Given this list of marker genes Cables2, Rhbdl3, Asb13, AA414768 (expressed sequence AA414768), Cmpk2, Synj2bp, Nxn, Mdga1, Rwdd3 (NCBI Gene Id 99697), Nfyc, Wars2, Trpm3, Lce3a, Idh1, Abi1, Kdm3b, Tax1bp3, Efcab5, Mbp, Atp2a2, Spen (NCBI Gene Id 56381), Scd1, Aak1, Gal3st2c, Timm9, Hnrnpdl, Pcdh17, Esp18, Ahcyl1, Usp49, Abcf2, Myo1f, Fbxo2, Crem, Tnfsf8, Gigyf2, Wfdc17 (WAP four-disulfide core domain 17), Neo1, Prkcb, Fbxw7, Nwd2, Wdr43, Gm10220, Gfral, Gpx5, Clint1, Rfx2, Adgrl2, Irf2, Cth, Nr2f2, Zbtb34, Glp2r, 5031410I06Rik, Tcf4, Timm50, Gpr157, Slc23a2, Dio1, Atp5mf, Klhl28, Dcc, Or12j5, Trabd2b, 2510009E07Rik, Stxbp1, Fuca2, Ago4, Ogn, Mthfd2l, Cd200r1, here is a description of the gene set: from publication Chen Y, Wang X (PMID 31504780) species: Mus musculus Genes predicted to be targets of miRBase v22 microRNA mmu_miR_3069_3p in miRDB v6.0 with MirTarget v4 prediction scores > 80 (high confidence targets). Mouse Gene Set: MIR_3069_3P